The following is a description of a gene set: Human Gene Set: HP_MALE_HYPOGONADISM Male hypogonadism species: Homo sapiens Decreased functionality of the male gonad, i.e., of the testis, with reduced spermatogenesis or testosterone synthesis., and this is the list of marker genes: IFT172, FSHB, ERCC6, FGFR1, NR0B1, GNRHR, FGF8, ANAPC1, SOX3, NHLH2, FGF17, KISS1, ERCC8 (ERCC excision repair 8, CSA ubiquitin ligase complex subunit), PROKR2, PROK2, LHB, SPRY4, ABCD1, AIP, MECP2, DUSP6, CDH23, WFS1, CYP17A1, SOX9, CNBP, AIRE, NR5A1, WDR11 (NCBI Gene Id 79207), KISS1R, TAC3, TACR3, SRY, MEN1, CISD2, ERCC4, GNRH1, POLA1, ERCC1 (NCBI Gene Id 2067), HS6ST1, CTNS, NSMF (NMDA receptor synaptonuclear signaling and neuronal migration factor), CHD7, DHH, EIF2S3, POLD1